Given this list of marker genes Mief1, Akt2, Fyn, Tcaf1, Stom, Cdk5r1, Chp1 (calcineurin-like EF hand protein 1), Ccl2, Cdk5, Prnp, Cacnb3, Tent2, Mtcl1, Pdzk1, Arpc2, Cemip, Grin2a, Mief2, C2cd5, Itgam, Itgb1bp1, Fis1, Slc51b, Erbb2, Actr3, Hpca, Myo1c, Cib1, Hras, Ank3, Kcnb1, Pak1, Mff, here is a description of the gene set: Mouse Gene Set: GOBP_POSITIVE_REGULATION_OF_PROTEIN_TARGETING_TO_MEMBRANE Any process that increases the frequency, rate or extent of the process of directing proteins towards a membrane, usually using signals contained within the protein. species: Mus musculus